Given this list of marker genes STK38, RFX5, TMTC4, RELB (NCBI Gene Id 5971), MBP, RAB11FIP1, NFKB2, RNASEL, CDCA5, DPY19L4, NGLY1, IGF1R, LTB, ATXN1 (ataxin 1), DAPL1, SCARB1, SSR3, RNF181, GFI1, FBXO25, MEPCE, DHRS13, ARHGEF4 (NCBI Gene Id 56770), MAD2L1, LPXN, ERI2, GPR68, PIK3IP1, IDH2 (isocitrate dehydrogenase (NADP(+)) 2), OARD1, CARD6, ASS1, NOPCHAP1, TES, TGFB1, GDI2, FAM117B, RHOF, AGO1, TOB1, STK10, NCMAP, PPP3CA, JCAD, VARS1, PLIN2, MTURN, INPP5F, SEC11A, COMMD8, BCL2A1, SLC30A1, CD9, B9D2, HDAC5, LANCL2, CORO2A, FOXP1, MGAT5, MXD4, FRMD8 (FERM domain containing 8), UNC93B1, HELLS, PTEN, TNFRSF4, AKIP1, TECR, SMC4 (NCBI Gene Id 10593), FADS2, C4orf46, TMCO4 (transmembrane and coiled-coil domains 4), TMEM106B, MMD, DEGS1, WDFY2, GIMAP1, GNAS, OSER1, UBE2E3, CASP2, S100A10, TBL1XR1, ATL3, CCDC28A, STX6, FAM3C (NCBI Gene Id 10447), WASF2, TAP1, AKT3, ZNF362, FDFT1 (farnesyl-diphosphate farnesyltransferase 1), MRPL45, MACO1, SMS, NEDD4, HMGB3, SAP30, MED30, CAPN3, BLCAP, NDRG1, ZNF250, PCK2, BNIP3L, FMNL3, VEZF1, RSPH3, RNF11, CDC25B, ENTPD1, ABI2, MRPS6, SFXN3, DGKD, CTLA4, ELL3, RBM38, SLC25A45, CEP57L1, ZNF703, DBP, EHD3, PNRC1, SYTL1, TRIM24, IGF2R, PTGR3, FILIP1L, SLC36A4 (NCBI Gene Id 360215), NATD1, ZYG11B, PDE3B, CUL7, STARD5, CCR8, HEMGN, RHOB, ANXA1, SESN1, AQP11, TAPBP, SLC16A10, PLCG1, DENND11, RANBP10, IFIT1, FDPS, RNF125, C3orf80, CYBA, NOD1, TLCD2, SLC2A3, SDCBP2, HLA-B, KIF21B, PPM1D, UBC, ITGA4, RAD52, ACCS, CFAP20, SRPK1, HROB, SLC6A6, ST8SIA1, ACSS1, TSC22D3, MCM7, DAP, APPL2, CPD, EWSR1, BATF3, NRP1, OTULINL, NFX1, CXCL10, TENT2, NTAQ1, RCAN3, GRINA (NCBI Gene Id 2907), NAA40, TXNIP, SLC43A2, BTG2, CCL5, FOXN3, HAUS1, RGS2, TTC3, MICAL1, GPCPD1, ARHGAP15, H1-0, TNFSF13B, RGS10, SCD, NSG2, HDAC7, here is a description of the gene set: Genes up-regulated in thymocytes: double negative versus CD4 single positive. T cells develop from progenitors that migrate from the bone marrow into the thymus. Thymocytes are subdivided roughly as being double negative (DN), double positive (DP), or single positive (SP), based on the expression of the CD4 and CD8 coreceptors. The DN stage is heterogeneous and can be subdivided into four distinct subsets in mice based on the expression of CD44 and CD25. In human, three distinct DN stages can be recognized: a CD34+CD38−CD1a− stage that represents the most immature thymic subset and the consecutive CD34+CD38+CD1a− and CD34+CD38+CD1a+ stages. Human DN thymocytes mature via an immature single positive (ISP CD4+) and a DP stage into CD4+ or CD8+ SP T cells that express functional T cell receptors (TCR) and that exit the thymus. In this study, gene expression was measured in each of these nine stages. Human Gene Set: GSE22601_DOUBLE_NEGATIVE_VS_CD4_SINGLE_POSITIVE_THYMOCYTE_UP species: Homo sapiens from publication Dik WA, Pike-Overzet K, Weerkamp F, de Ridder D, de Haas EF, Baert MR, van der Spek P, Koster EE, Reinders MJ, van Dongen JJ, Langerak AW, Staal FJ (PMID 15928199)